Given this list of marker genes MIR766, F3, PRKD2, MIR488, CD244, NOD2, SERPINE1 (serpin family E member 1), MIR302C, LGALS9, SSC5D, DDIT3, TLR7, HSPA1B, ANXA4, C5AR2, ADIPOQ, KLF4, TLR9, BCL10 (NCBI Gene Id 8915), STAT3, CD14, MIR506, TLR2, RAB1A, MIR181A2, NOS2, F2RL1, CACTIN, ANXA1, MIR146A (NCBI Gene Id 406938), MIR129-1, NLRP10, IL6R, MIR106A, IL17F, MIR203A, MIR520C, CD58, PRG3, PTPN22, RELA, MAVS, MYD88, PYCARD, MIR100, ZNF580, CD74, RIGI, MAPKBP1, PLA2G1B, CRP, CAMP, PTPRC, CD2, GDF2, LAMTOR5, TLR4, MIR302D, CLEC7A, CALCA, TLR6, HMGB1, ELANE, CD33, HSPA1A, MIR132, APOA2, MIR204, MIR520B, SYK, MIRLET7C, TNF, MIR93, CHI3L1, MIR106B, ARRB1, MIR98, MIR920, IL17D (NCBI Gene Id 53342), LBP, TLR1 (NCBI Gene Id 7887), AFAP1L2, F2R, TIRAP, IL6, TLR8, IL10, RIPK1, LEP, PARK7, WNT5A, IL1B, FCN1, HYAL2, BPI, BCL3, FFAR2, TLR3, TLR5, NOD1, LILRA2, MAP2K5, OTUD7B, FADD, DEFA5, here is a description of the gene set: studied in species Homo sapiens The appearance of interleukin-8 due to biosynthesis or secretion following a cellular stimulus, resulting in an increase in its intracellular or extracellular levels. Human Gene Set: GOBP_INTERLEUKIN_8_PRODUCTION